Given this list of marker genes GNAQ, CHRNE, PYROXD1, DNAJC30, ELN, KDM6A, MEGF8, GPC4, MMP20, SUMO1, BRAF, HNRNPK, METTL27 (NCBI Gene Id 155368), ERCC6, MSX1, FREM2, TTI2, SOS1, ARHGAP29, POLR1B, IRF6, NHS, SMAD3, RDH11, FGFR1, CA2, TMEM270, POLR1D, KMT2D, DDX59, GTF2I, SLC39A13, FAM83H, PLCB4, AMER1, GFPT1, HSPG2, BAZ1B, EDN1, CHRNG, EDARADD, DLG1, SATB2, SMCHD1, GPC3 (glypican 3), MARS1, VPS37D, PAX9, MAP2K1, GRIP1, SH3BP2, BANF1, RELT, SHANK3, GTF2IRD2, ASPH, SMARCA2, PDGFRA, RIC1, TRIM37, PTPN11, NECTIN1, IL11RA, TCF12 (transcription factor 12), FGFR2, CDC42, DCHS1, FLCN, GTF2IRD1, IRX5, GJA1, PORCN, NCF1 (NCBI Gene Id 653844), MLXIPL, THOC6, FGD1, SKI, TSPAN7, FRAS1, MTM1, TCIRG1, MYOD1, TRPS1, NOTCH2, WNT10A, TBL2, CREBBP, DOCK3, LRP6, TCOF1, LIMK1, TWIST2 (NCBI Gene Id 117581), RHOA, DSPP, RFC2, PIK3CA, BMP2, SH3PXD2B, COBLL1, GNAS, BCOR, CLCN7, GPR68, PIK3R1, DPM2, PRKAR1A, AMELX, FLNA, POLR1C, PCGF2, ITGB6, FGFR3, BRF1, TP63, ATR, ERCC8, EIF4H, DVL3 (dishevelled segment polarity protein 3), PCYT1A, BUD23, CDH1, ARHGEF38, BRCA1, ENAM, TGFA, SOST, BMP4, PLEKHM1, GLI2, AGO2, ATP6V1B2, FAT4, EP300, KCNN3, GNAI3, PAX1, STX1A, WNT10B, CDH11, EDA, ACP5, OBSL1, AXIN2, LRP5, DVL1, ABCC9, RPS6KA3, CTSK, ANKH, GRHL3, GPR101, DLX4, EFEMP1, CLIP2, AIP, KCNH1, FKBP6, KLK4, here is a description of the gene set: species: Homo sapiens Dental malocclusion Human Gene Set: HP_DENTAL_MALOCCLUSION Dental malocclusion refers to an abnormality of the occlusion, or alignment, of the teeth and the way the upper and lower teeth fit together, resulting in overcrowding of teeth or in abnormal bite patterns.